Given this list of marker genes FGFR2, COL1A2, HES7, ANTXR1, CEP120, PAX7, XYLT1, COL11A2, CSF1R, DYNC2I2, DDRGK1, HHAT, SNRPB, COL11A1, BMPER (BMP binding endothelial regulator), KDELR2, UBE3B, DDR2, CSPP1, COL2A1, INPPL1, FLNB, TBX15, COL1A1, TRIP11, CANT1, SLC26A2, KIAA0586, CSGALNACT1, IFT172, ABCD4, PAM16, PEX1, here is a description of the gene set: The rib cage has the shape of a wide mouthed bell. That is, the superior portion of the rib cage is constricted, followed by a convex region, and the inferior portion of the rib cage expands again to have a large diameter. Human Gene Set: HP_BELL_SHAPED_THORAX species: Homo sapiens Bell-shaped thorax